The following is a description of a gene set: A major goal of cancer research has been to identify genes that contribute to cancer formation. The similar pathology between zebrafish and human tumors, as well as the past success of large-scale genetic screens in uncovering human disease genes, makes zebrafish an ideal system in which to find such new genes. Here, we show that a zebrafish forward genetic screen uncovered multiple cell proliferation mutants including one mutant, crash&burn (crb), that represents a loss-of-function mutation in bmyb, a transcriptional regulator and member of a putative proto-oncogene family. crb mutant embryos have defects in mitotic progression and spindle formation, and exhibit genome instability. Regulation of cyclin B levels by bmyb appears to be the mechanism of mitotic accumulation in crb. Carcinogenesis studies reveal increased cancer susceptibility in adult crb heterozygotes. Gene-expression signatures associated with loss of bmyb in zebrafish are also correlated with conserved signatures in human tumor samples, and down-regulation of the B-myb signature genes is associated with retention of p53 function. Our findings show that zebrafish screens can uncover cancer pathways, and demonstrate that loss of function of bmyb is associated with cancer. Human orthologs of genes down-regulated in zebra fish after knockdown of BMYB by morpholino. Human Gene Set: SHEPARD_BMYB_MORPHOLINO_DN studied in species Homo sapiens from publication Shepard JL, Amatruda JF, Stern HM, Subramanian A, Finkelstein D, Ziai J, Finley KR, Pfaff KL, Hersey C, Zhou Y, Barut B, Freedman M, Lee C, Spitsbergen J, Neuberg D, Weber G, Golub TR, Glickman JN, Kutok JL, Aster JC, Zon LI (PMID 16150706), and this is the list of marker genes: VSX2, MASTL, CFB, SRSF9, TCN2, NDE1, ACSF2, GCH1, TTK, APOA4, SLC2A5, PARPBP, DNMT1, DCK, F7, STRA6 (signaling receptor and transporter of retinol STRA6), ANOS1 (NCBI Gene Id 3730), GINS1, DRAP1 (DR1 associated protein 1), MGAT4B, ITGB4, ANLN, IGFBP1, BHLHE22, PTPRN (protein tyrosine phosphatase receptor type N), PHF20L1, DHFR, CPVL, COL4A5, LIPG, MDK, HEY1, TK1, DAP (NCBI Gene Id 1611), MTHFD1L, RTKN, SLC4A2, TOX3, ATP1A1, SEPTIN6, SCIN, KIF11, DLGAP5, ACAP2, MT2A, VTN, TSPAN2, CDCA2, BIRC5, MIEN1, NUMA1, PLP1 (NCBI Gene Id 5354), PSAT1, SLX1B, TXNIP, MDM4, FGA, SUMO1, TGM1, FBXO5, IRF2BPL, RBP4, MKI67, HNRNPA2B1, PCK1 (NCBI Gene Id 5105), CA1 (NCBI Gene Id 759), PRR11, CEBPD, HES5, ASPM, GALC, KIF14, NOTCH2, GRHPR, BLVRB, POU3F3, DUT, FGFR4, POU3F2, LYZL6, RGS2, PRKCB, AEBP1, PMP22, C3, PVALB, KRT17, RAX (NCBI Gene Id 30062), SERPINC1, IGFBP2, KRT32, NR2E1, SLC25A24, APOE, HELLS, PFKFB4, ACSS2, TNXB, MCM4, MCM5, CHERP, SARDH, INKA2, PDCL, ELAVL4, PRB1, MELK, TM7SF2, DDX17, SLC29A2, CDC6, AQP1, SULF1, POU3F1, ASCL1, FAHD2A, HOGA1, GPT2, EPDR1, S1PR1, CDCA7L, TACC3, DLX1, MYH8, COL1A2, SLC6A13, CEACAM20, FGG, KRT2, CDC20, C8G, FABP7, SOX11, CIDEC, S100A10, PRC1, TTN, MCM2 (NCBI Gene Id 94687), SOX21, GTSE1, INPP4A (NCBI Gene Id 3631), AQP3, CENPM, WDR76, UHRF1, CCNB3, ARHGEF10, CLDN1, ACAT2, GINS2, PYGL, MCM3, NSD1, LAMP2, CCNB1, RGS4, KIF23, SFRP1, HLX, MAB21L2, OTP, SYNGR1, PRODH2, NR2F1, CDCA3, PAXIP1, CCNG2, CEBPA, GOLGB1, EOMES, BMS1, CDK1, LHX1, SFXN2, NR0B2, GPSM1, FOXM1, CDC14B, MSH2, PTPN22, AURKB, IQGAP3, DLX2, CTSL, TOP1MT, HMGA1, PRIM1 (NCBI Gene Id 5557), PPP1R3G, UCP2, DBX1, PCDH18, LIG1, GMNN, COL1A1, TPX2, ORC4, CDK2, CKAP2, NOVA2, C17orf49, COTL1, ARID5B